Given this list of marker genes Tnf (NCBI Gene Id 21926), Rock1, Rps6, Ikbkb, Rps6-ps4, Rock2, here is a description of the gene set: Any process that stops, prevents or reduces the frequency, rate or extent of tight junction assembly. Mouse Gene Set: GOBP_NEGATIVE_REGULATION_OF_BICELLULAR_TIGHT_JUNCTION_ASSEMBLY studied in species Mus musculus